The following is a description of a gene set: studied in species Homo sapiens Human Gene Set: MIR4690_3P Genes predicted to be targets of miRBase v22 microRNA hsa-miR-4690-3p in miRDB v6.0 with MirTarget v4 prediction scores > 80 (high confidence targets). from publication Chen Y, Wang X (PMID 31504780), and this is the list of marker genes: GRIPAP1 (NCBI Gene Id 84538), ZNF330, VWA8 (von Willebrand factor A domain containing 8), HNRNPR, KDM6A, CPT1A, PHF21A, TMEM127, ARHGAP21, TNRC6A, LYSMD1, OCLN, NMT1, MZT1, ZDHHC8, GPBP1, TRIQK, FAM76A, TESK1, CNR1, KDM3B, INHBB, GPRASP3, ITPRIPL2, KIAA1549, HABP4, ADCYAP1R1, KCND1, TREML2, EVC, RIMS3, WFDC2, CFL1, GRB2, STAC2, ADSS2, GINS2, KSR2, STRBP, INKA2, EMILIN2 (NCBI Gene Id 84034), CNTNAP2, FAM217B, UBE2D4, MMP14, MMD, RAB31, PLEKHA3, SGPP2, SUFU, GALNT15, BCAP29 (B cell receptor associated protein 29), ALG13, VAMP3, NAA50, LRRC4, TBC1D8B, KRBOX5, ATP8B1, N4BP3, CERT1, INPP5A, ZDHHC18, STAG2, ASB1 (ankyrin repeat and SOCS box containing 1), C9orf72, DDX6, STK32B